The following is a description of a gene set: Lack of strength of the proximal musculature occurring late in the clinical course. Late-onset proximal muscle weakness species: Homo sapiens Human Gene Set: HP_LATE_ONSET_PROXIMAL_MUSCLE_WEAKNESS, and this is the list of marker genes: KCNE3, CRYAB, DES, GABRA3, KCNJ18, SCN4A, CACNA1S, HNRNPA1